Given this list of marker genes Zfp945 (zinc finger protein 945), Rfx3, Cdc73 (cell division cycle 73, Paf1/RNA polymerase II complex component), Eif4enif1, Acer3, Arpp21, Dusp7, Cep295, Evi2b, Brwd3, Cops2, Il21, Pstpip2, Abraxas1, Prlr, D630023F18Rik, Zbtb43, Mrgpre, Pramel22, Pramel27, Spef2, Sorcs3, Manea, Kras, Lamp2, Wdr33, Steap2, Fgf7, Smoc2, Gm12253, Crebrf, Rab7, Htr3b, Prokr2 (prokineticin receptor 2), Snurf, Serp1, Pcdh10, Ppp1r1c, Fancd2os, Stum, Heyl, Galnt12, Kcnab2, Pfkfb2 (6-phosphofructo-2-kinase/fructose-2,6-biphosphatase 2), Cyria, Tasor2, Tnfsf15, Spn, Ldb3, Or51ab3, Lrrn4cl, Usp25, Tcf7l2 (NCBI Gene Id 21416), Cdc23, Csf2rb2, Homer1, Ifi202b, Dusp16, Car5b, Clrn1, Gpatch8, Sarnp, Zfp967, Ptprk, Col4a5, Papss2, Slc5a8, Trub2, Cacna1g, Pank3, Zfp729a (NCBI Gene Id 212281), Pank1, Ccpg1, Cdh11, Oxgr1, Amotl1, Crppa, Jhy (NCBI Gene Id 70989), Fam120c, Cplx2, Camta1, Cemip, Hivep1, F830016B08Rik, Gbp4, Lcorl, Csf2rb, Ell2, Rock2, Gadl1, Ago3, Clec5a, Foxc1, Naa11, Cdk8, Acot8, Samt4, Ptbp3 (NCBI Gene Id 99962), Rnf220, Nsd2, Zfp1009, Ntrk3, Cimip2b, Or12j5, Zfp970, Prr11, Ro60, Ajap1, Brinp1, Ppp6r2, Ypel5, Trmt12, Tbc1d24, Slc35d2, Dclre1c, Arhgef33, Tfap2b, Bcl2, Xrcc3, Sfi1, Slc12a1, Myo9a, Dnm3, Cpsf2, Glcci1, Aldh1l2, Vwc2, Wsb1, Wdr82, Gabrb3, Zfx, Sim1, Nrxn1, Zfp966 (zinc finger protein 966), Arhgap25, Nxpe3, Gm94, Azin1, Zfp831, Kcnj3, Extl3, Zfp729b, Il18r1, Mindy2, Itgb1bp1, Plaat3, Tomt, Fech, Elapor2, Fmn2, Snrpn, Atrn, Ice1, Olfm3, 6030458C11Rik, Zfp26, Insm1, Bltp3b, Epc1, Csnk2a2, Lrch1, 4930444P10Rik, Heph (hephaestin), Ano4, Gria4, Serpinb1a, Oprd1, Depdc5, Slco3a1, Ids, Riox2, Gnaq, Dpp4, Epyc, here is a description of the gene set: Mouse Gene Set: MIR_297A_5P species: Mus musculus Genes predicted to be targets of miRBase v22 microRNA mmu_miR_297a_5p in miRDB v6.0 with MirTarget v4 prediction scores > 80 (high confidence targets). from publication Chen Y, Wang X (PMID 31504780)